Given this list of marker genes Slc22a6, Slc22a7, Slc13a5, Slc13a2, Slc25a21, Slc13a3, Slc25a11 (solute carrier family 25 (mitochondrial carrier oxoglutarate carrier), member 11), here is a description of the gene set: species: Mus musculus The directed movement of alpha-ketoglutarate into, out of or within a cell, or between cells, by means of some agent such as a transporter or pore. Mouse Gene Set: GOBP_ALPHA_KETOGLUTARATE_TRANSPORT